The following is a description of a gene set: studied in species Homo sapiens Decreased body weight Abnormally low body weight. Human Gene Set: HP_DECREASED_BODY_WEIGHT, and this is the list of marker genes: BCL2, NDUFAF1, FTH1, COL6A1, PIGP, ATP7B, POU6F2, KARS1, TRAIP (NCBI Gene Id 10293), LUZP1, MBL2, SUGCT, GLI2, PNPT1, CCNF, NSRP1, DDC, HTRA2, RHBDF2, FBN1, LCK, EBF3, NEFH, TWNK, AK2, IL2RG, CIC, SHH, OTUD6B, COL1A2, SLC25A3, BRCA2, COX7B, EDNRA, PPP1CB, SPRTN, HADHA, RFWD3, CASZ1, CUL3, POLD1, SNCA, INSR, KLHL41, GLYCTK, NELFA, PALB2, TGFBR2, FARSB, NCAPG2, SLC25A22, ASNS, HACE1, DNA2, ALS2, TRIM37, XPC, CHEK2, PHKG2, TTR, IFNG, RELB, CA2, DPP9, CCDC47, POMP, PRNP, SZT2, SUCLG1, PIGA, COG8, CYP24A1, BANF1, SLC7A7, KCNN4, MAP3K20, CFAP410, NCF1, NDUFA2, NKX3-2, LPIN2, MALT1, TAC3, ITGAM (integrin subunit alpha M), RTTN, TET2, SIX3, PEX7, LRRK2, IFIH1, OBSL1, ICOS (NCBI Gene Id 29851), NDUFS2, ACTB, RPL5, TRIP13, SYK (spleen associated tyrosine kinase), FANCA, SMC3, ATP8B1, ADK (NCBI Gene Id 132), CYP19A1, RNU4-2, PKP1, EWSR1, SDHAF1, SIN3A, SHOC2, DTYMK, NPHP3, MRAP, TRAK1, ANKRD55, ROBO1 (roundabout guidance receptor 1), CTNNB1, NFKB1, FAM111A, COL4A6, TRAC, ZEB2, YWHAG, LAMA2, CDON, TACR3, CTRC, CA12, CHRNA3, CDKN1C, TBR1, PXK, PIGQ, KISS1 (KiSS-1 metastasis suppressor), SNIP1, ABCB11, HSD17B4, TLL1, TRMT1, YARS2, SIK1, PTRH2, NACC1, RPS15A, ZNF335, FANCD2, PEX19, PTEN, MT-TQ (NCBI Gene Id 4572), MARS1, BAP1, HACD1, MECP2, CAMKMT, MMAA, SIL1, CPSF3, WNT7B, MT-ND2, RPS29, PTH1R, SCN1A, ERCC5, NPM1, TCTN3, PPFIBP1, HLA-DRB1, ADA, FANCM, SPEN, AUTS2, DOCK6, HSD11B2, ANTXR2, PPP1R13L (protein phosphatase 1 regulatory subunit 13 like), POLG2, WDR73, PLCB1, GJA1, FANCC, EVC2, RFT1, NDUFS4, NAB2, SNORD115-1, SLC35C1, GLT8D1, IRF4, MS4A1, CRELD1, MT-ND6, KAT6B, NSUN3, STING1, AKR1D1, GATA2, PLP1, MBTPS2, DYNC2LI1, BCL6, GABRD, RPL35A, RPL26, STAT4, MEG3, ATP1A2, UBR1, EN1, MCCC2, SLC39A8, ZIC3, EARS2, VPS37D, NALCN (sodium leak channel, non-selective), GGPS1, BMP4, NNT, KCNB1, FCGR2A, GABRA2, DAO, HLA-DPB1, VIPAS39, HESX1, UNC13A, CRIPTO, ZNRF3, POLR3K, MMUT, TLR7, BSND, KIF15, LIN28B (lin-28 homolog B), TYMP, NOTCH2NLC, STT3B, TYMS (NCBI Gene Id 7298), FGFR1, CBS, HIBCH, MYO5B, NSF, ADAR, BSCL2, COX4I1, FANCL, NDUFAF6, SDHB, PRDX1, KISS1R, ARPC1B, MAP2K1, LIMK1, FLCN, LMNB1, MRPS7, CEP152, UQCRC2 (NCBI Gene Id 7385), ASPM, CHRM3, DHCR24, SYNJ1, VARS2, WDR26, DHDDS, AMACR, TMEM127, HADHB, ERBB2, DNASE2, PYCR1, HADH, GALT, ESAM, LAT, PEPD, WWOX, DEF6, NAGS (NCBI Gene Id 162417), BLK, TAF6, CHD7, ANKH, WDR4, CDT1, TGIF1, B4GALT1, CDKN2B, CENPT, COG4 (component of oligomeric golgi complex 4), MLX, CACNA1S, ALG6, BTNL2, CEP57, ATP9A, HCCS, MTRFR, MSH2, ALG11, ABCA3, PRF1, ATXN7, TIMMDC1, AP3B2, GTF2IRD2, PON1, IFT140, ALG8, STAG1, TOPORS, LETM1, NR3C2, FKBP6, FOXP3, JMJD1C, GCK, HPDL, RAC2, MATR3, SIGMAR1, DGAT1, VAC14, POMC, CELF2, CACNA1B, THRB, DGUOK, PRMT7, MYL2, FUS, GTPBP2, TGFB3, YY1AP1, RPL18, B3GLCT, ENPP1, SAMD9, NEUROD2 (NCBI Gene Id 4761), RNF2, FLI1, CAPNS1, GNB1, UBAP2L, NDUFA8, RPS20, MEFV, RPS19, PERCC1, FIP1L1, HNRNPH1, SLC1A2 (solute carrier family 1 member 2), VPS13B, ASH1L, KRT10, CDKN1A, IL1RN, NDUFS8, EHMT1, MTHFR, ASXL3, ERBB4, KRAS, AFG2A, TAFAZZIN, EIF2S3, ACADM, PPM1B, SLC39A7, PFN1, MMADHC, YIPF5, NOD2, HNRNPA1, TNPO2, TCF3, NSMCE3, SLC25A19, ASAH1, SLC3A1 (NCBI Gene Id 6519), ORAI1, SDR9C7, CNKSR2, FIG4, PREPL, PGM3, NSMF, EPAS1, SMARCC2, SLC6A8, PDHA1, NDUFAF3, NCAPD2, IL6, VAPB, GNAO1, PDE6D, KCNA4, TRIM28, IFNGR1, DOCK11, TNFRSF13B, PEX5, DNMT3A, KDSR, KRT1, LIG4, MT-TK (NCBI Gene Id 4566), NUDT2, POU1F1, GMPPA, TFAM, HLA-B, CNTNAP1, NDUFAF5, FBXL4 (NCBI Gene Id 26235), NF1, BICRA, TERT, C4A, POLG, ZFP57, PTCH1, MC2R, EXOSC3, PGAP1, GRB10, LARP7, MT-TF, NFKBIL1, ASS1, PRPH, DISP1, CEACAM6, PSMB4 (NCBI Gene Id 5692), NDP (norrin cystine knot growth factor NDP), SIX2, MAD2L2, PIK3CD, SSR4, PSMD12, IGF2, PML, SCNN1B, TMEM165, IL12A, RAG1, NRCAM, POC1A, FUT8, CERS3, LAMC2, CDK10, LMBRD1 (NCBI Gene Id 55788), EDN3, TRIM8, TREX1, SLC32A1 (solute carrier family 32 member 1), TRPV4, CPS1, TRIT1, SELENON, VPS45, DNM2, MED17, UBTF, PLCH1, DCTN4, OCA2, MUTYH, TALDO1, NDN, ATPAF2, CBL, SMOC1, MT-TV, FAS, BUB1B, GATA1, CDKN2C, SLC51A, IL23R, TINF2, BMP6, DDX3X, STAT3, IRF6, MARS2, SCN3A, SEMA4D, KMT2D, MVK, PSAT1, IGLL1, FGF17, ORC4, GRIN2D, FLT1, GHSR, SRD5A3, FOXH1, CPLX1, DCTN1, SBDS, CLMP, ECE1, KIT, ABCD1, DLST, IL2RB, CAVIN1, SEMA3D, C4B, SLC25A4, PPP2R3C, KRT16, PACS2, MCCC1, OCRL, EP300, PON3, HMOX1, RPL15, ACAT1, AGR2, MT-TL1, ACVR1, PROKR2, CLIP2, TBC1D24 (TBC1 domain family member 24), RRAGC, TRAPPC11, CTLA4, KCNJ1, GPR161 (G protein-coupled receptor 161), ATP1A3, P4HA2, GJA5, WRN, ATP7A, PLK4 (NCBI Gene Id 27119), DYNC2I1, GUF1, RPL11, PLCB4, ALDOB (aldolase, fructose-bisphosphate B), NOS1, SLC4A10, SLC1A3, BMPR1A, RPS24, NDUFA6, RNF168, UBE4B, SI, GRIN2A, SCO1, MYMK, NDUFB7, EBP, GATA6, VPS13C, SCN8A, GRIN1 (glutamate ionotropic receptor NMDA type subunit 1), BLNK, AKT1, CASR, CLCN3, GALK1, IL12B, ALOXE3, EPG5, PNPLA6, TGFB1, ANO1, SHROOM4, G6PC3, MYH7, BCOR, KRT14, F5, WDR62, BRF1, IGF1R (insulin like growth factor 1 receptor), NODAL, PMM2, MT-CO3, MAP2K2, SCN1B, CUBN, NDUFAF8, FCGR3B, TNFRSF13C, HFE, BCS1L, SLC30A9, TMEM106B, NDUFB11, DIS3L2, ALG12, PRKACA, VHL, FDXR, DNAJC19, SLC6A14, RILPL1, POLA1, PUS7, UBA5, ARID1B, CYP11A1, TOM1, IVD, NEDD4L, CNTN1, STIL, AMN, CD3D, RAB33B, RNU7-1, RRM1, ATP5F1A, SMARCAL1, ATP6V0A2, RBBP8, EEF1A2, COL7A1, ETHE1, BRD4, EXTL3, NFKB2, TNNT1, NEB, FGF8, TNFRSF11B, MCEE, GRM7, KIF22, DUSP6, WNT2B, PPARG, GALE, IPO8, CYFIP2 (cytoplasmic FMR1 interacting protein 2), TNFRSF1B, LARS2, MSMO1, DIAPH1 (diaphanous related formin 1), CYC1, TPM3, ASCL1, NCAPH, SCO2, COG1, RPL27, TOP3A, RARB, DDOST, B3GALT6, RNF13, SKI, CYP2R1, IGHG1, HS6ST1, CYP17A1, PTF1A, DLD, PPP1R15B, FLNA, STOX1, SLC9A6, CUL4B, DHCR7, DPAGT1, IDH1, NTRK2, HSPG2, MT-ND1, ADCY5, SPOP, GLE1, PUF60, EXOSC9, GTF2E2, ASL, FGF12, PSAP (NCBI Gene Id 83009), TPM2, OTULIN, AGXT, MTRR, GNRHR, PTPN22, RRM2B, PMS2, NUP54, USF3, MPL, GMNN, ANAPC1, TTN, MYH3, NEXMIF, SLC25A15, BMP1, FAH, UBE2L3, NFE2L2, THOC2, AMPD2, NDUFS7, TMEM231, RPS10 (ribosomal protein S10), ACD, NEUROG3, COL12A1, STAT5B, MAMLD1, MIF, PCNT, PWRN1, TMEM216, ANKLE2, PON2, CCNQ, SLC37A4, PDHB, ALG3, TLR4 (NCBI Gene Id 7099), AR, LAMB3, THPO, UNC80, CAD, CLCNKA, RPL31, RUNX1, CIITA, UMPS, RYR1, FANCF, STAR, COX10, IKZF1, PEX13, TMEM126B, PANK2, TIMM22, GIPC1, UPF3B (NCBI Gene Id 65109), JPH3, ATP6AP1, RABL3, JAGN1, MT-CO1, DLL1, GNPAT, FZR1, INTU, ALK, GTPBP3, SREBF1, POLR1B, NCAPD3, CHRNG, RAPSN, PACS1, CUL7, CLDN16, PEX16, RMRP (NCBI Gene Id 6023), TREM2, SUCLA2, STAMBP, SEC31A, EIF5A, TRMT10C, SLC11A1 (NCBI Gene Id 6556), NFASC, MAGEL2, FMR1, RNU4ATAC, KCNJ11, EIF2AK3, H4C5, ALG2, HBA2, ERCC3, ASXL1, EFL1, FANCB, CTBP1, KLLN, MRPS16, UFD1, CRIPT, COG7, SQSTM1, KBTBD13, SLC10A2, CYP27B1, RAD51, PROK2, NFU1, AGPAT2, PCGF2, WBP4, TSHR, MITF, COL1A1, PDPN (podoplanin), ZMPSTE24, ATR, FOCAD, LRRC8A, CASK, ATM, RFXANK, CIT, FOS, LYRM7, SLC26A2, SMO, XRCC2 (X-ray repair cross complementing 2), NECTIN1, GPC3, HIVEP2, MT-ND3, RPS7, VPS35 (NCBI Gene Id 91808), HEATR3, ESR2, SPP1, CACNA2D1, MUSK, POLR1C, NDUFB10, KIAA0586, ACADS, COG6, ALAD, BAZ1B, AP1B1, NGLY1, TCIRG1, PCCB, LGI3, AHCY, AGTPBP1, CD3G (CD3 gamma subunit of T-cell receptor complex), TAMM41, GPIHBP1, ATRIP, ITGA7, PQBP1, TASP1, CARS1, SPTSSA, ARFGEF2, PRKCZ, BRIP1, EXOSC8, HCFC1, UBE2T, LRP12, UQCRFS1, MRPS14, METTL5, BPTF, AAAS, AIMP1, GBE1, ERCC8, SON, NUP85, EFEMP1, INS, NADK2, RAB3GAP1, NDUFA1, SKIC2, SLC25A11, BIRC3, LIPA, NOTCH2, SLC16A2 (solute carrier family 16 member 2), GAS1, HAVCR2, ACADVL, SPTBN1, ZNF668, TMEM70, RPS17, MT-CO2, KIAA0319L, AFF3, NKX2-1, ERAP1 (endoplasmic reticulum aminopeptidase 1), RPS28, NDUFB3, STAT1, NDUFA13, TFRC, KCNQ2, IKBKB, NFKBIA, PHGDH, CDKN1B (cyclin dependent kinase inhibitor 1B), COL4A5, CDC73, CCR1, CSPP1, CYP7B1 (cytochrome P450 family 7 subfamily B member 1), FOXRED1, RAD51C, KCNJ18 (NCBI Gene Id 100134444), GLI1, ELMO2, COQ4, CDH23, MRPL39, MIPEP, CD96, PKHD1, SPINK5, PLAA, SATB1, ST3GAL5, CKAP2L, HNRNPK, UFC1, LYN, GBA1, IL21, BUD23, RIT1, HERC2, TCF4, XYLT2, FZD4, RERE, IFT56, GNPTAB, CRLF1, SLC34A3, TBL2, EIF4G1, MKKS, ADA2, ERBB3, NECAP1, RAD21, CSF2RA, PYCR2, AGPS, SLC9A3, PNP, NPHS1 (NPHS1 adhesion molecule, nephrin), ACTG1 (NCBI Gene Id 71), TBX1, PAM16, SPG11, GABRB2, ORC6, TGDS, ANOS1, SYNGAP1, PTPN11, NUMA1, GCLC, SMAD4, GCDH (NCBI Gene Id 2639), GYS2, CLTC, CR2, CTNS, XPA, SRP54, TNIP1, IQSEC2, SMAD2, GABRA3, LRRK1, HBA1, HIKESHI, CD244, HMGA2, LARS1 (NCBI Gene Id 56885), IGF1, IGHMBP2 (NCBI Gene Id 50985), PSMB8, COPB2 (NCBI Gene Id 9276), ATP6V1A, CYB5A, COX20, TNFAIP3, SH3TC2, HYMAI, RAI1, UQCC2, SLC46A1, UBAC2, ERCC4, GDNF, BRCA1, HNF1A, MYT1L, SRSF2, MTO1, GRIA4, SPTLC1, KRT17, DOLK, ALB, SLC25A24, SLC2A3, GLUD1, MDH2, SLC22A5, NDUFA11, MYL11, KIAA0753, DNM1L, CARMIL2, IRF2BP2, SLC5A1, TKFC, EGFR, AARS1, GALC, CD247, BTK, PBX1, TARDBP, NDUFS1, PWAR1, ABCD4, TBX4, KMT2C, MAP3K7, STRADA, DEGS1, AASS, SLC12A3, MPI, HRAS, RPS6KA3, SPI1, HLA-DQB1, SNAP29, SLC25A13 (NCBI Gene Id 10165), KDM5C, NUBPL, OCLN, SC5D, KCNJ6, SMARCD2, FGD1, CHMP2B, TNFSF12, TP63, TAOK1, ACOX1, GLB1, CNOT1, SGO1, IL21R, POLR1A, NDUFV1, POLE, SEMA4A (NCBI Gene Id 64218), DEAF1, SPINK1, CENPJ, MMACHC, TCN2, RPL8, TJP2, CREBBP, PMS1, KLF1, EOGT, ARCN1 (archain 1), NFIA, TUBB4A, GSTM3, NHLRC2, ACO2, SFTPC, SLC39A4, SLC13A5, SH2B1, DDB2, PUS3, UNC45A, HTT, CAV1, CD81, MLH1, NFIX, FH, NDUFA4, RIPK1, DRG1, VPS37A, UBA2, DOCK8, CLTCL1, CFTR, JAK1 (Janus kinase 1), STUB1, ABCC6, FOXP1, ERCC1, FLII, SMPD1, PEX12, JAG1, TRIO, GNRH1 (NCBI Gene Id 2796), NLRC4, PYGL, H3-3B, SLC26A3, CORIN, FBXO28, PLAGL1, DPYD, SLC38A3, MT-ND5, ZNFX1, GJA8, PEX1, CLCA4, MT-TN, ARVCF, SDHA, ANXA11, AUH (NCBI Gene Id 549), ACTL6B, CD79B, SOD1, ELAC2, DYM, TMPRSS15, PNPO, NDUFB8, FANCG, AMER1, OSGEP, PDX1, MT-ATP6, ALPL, DPP6, MSX1, DNM1, SPRY4, MPV17, MSH6, GOT2, DNAJC13, HNRNPH2, SMARCA2, KMT5B, RFX5, ITCH, DLL4, ALG13, PEX3 (NCBI Gene Id 8504), PSMC1, TONSL, REST, POR, ATP5F1B, PEX10, MCM4, AVPR2, ABCC8, VPS51, HUWE1, TAPT1, HLA-DPA1, GATA4, DKC1, KMT2A, KRT6A, CDC6, EMG1, TBC1D23, IL10, NR4A2, GTF2H5, RPL35, MKRN3, CHCHD10, PRDM16, EIF4A2, MT-TS2, KCNAB2, ACAD9, MECR, CSNK2A1, UBE3B, MPDU1, RARA (NCBI Gene Id 5914), PIK3CA, GTF2IRD1, CBFB, TBK1, PPARGC1A (PPARG coactivator 1 alpha), GOLGA2, NDUFS3, IGHM, SALL1, SNRPN (small nuclear ribonucleoprotein polypeptide N), GPR35, SNX10, CYP11B2, LMO1, STT3A, TXNRD2, IL12A-AS1, FOXG1, STX1A (syntaxin 1A), MAPKAPK5, CENPE, SLC12A5, GAA, PCLO, MCTP2, CDKN2A, SDHC, RFC2, ATRX, MCM9, VPS33B, PIK3C2A, MT-ND4, SETD2, SERPINA1, DLK1, ERMARD, SARS1, CCDC8, SEC23B, DYRK1A, MGAT2, YY1 (YY1 transcription factor), MEGF10, NDUFAF2, CDC45, CRLS1, TMEM270, UBQLN2, PEX6, SCN2A, NUS1, HBB, ARX, FUCA1, SLC2A2, ELF4, AVP, SLC34A2, RTEL1, SCNN1A, SLC35A2, ETS1, RBM10, RB1, CAMK2B, NCF2, RPL9, ADAM17, RBPJ, DPYS, PALLD, ZIC2, NUP214, DALRD3, LEMD3, RPS26, VRK1, STAT6, AHDC1, PCSK1 (NCBI Gene Id 5122), NR0B1, TSHB, FAM149B1, LMNA, ADNP, GJB3, PRKACB, STAG2, DMPK, POGZ, MYMX, IL7R, HSD3B7, WDR11, CD28, WT1, CDKL5, OTUD5, ANG, KCNA2, IKBKG, DNMT3B (NCBI Gene Id 1789), GALM, DNASE1, IRF5, ZBTB16, RFXAP (NCBI Gene Id 5994), VPS13A, NDUFAF4, MEN1, TNFSF4, DCLRE1C, STRA6, SETBP1, VCP, NLRP1, PEX2, TSR2, MBTPS1, GPD1, MYPN (NCBI Gene Id 84665), TAF13, ATP6V0A4, SV2A, JAZF1, RBCK1, TRMT10A (NCBI Gene Id 93587), VPS53, BCAP31, MRPS2, CPLANE1 (NCBI Gene Id 84157), LTC4S, JAK2, ELN, RECQL4, GNB2, VDR, PTS, JAK3, ZNF699, FBN2, NDUFV2, TAF15, PLAG1, SEMA3C, ORC1 (NCBI Gene Id 4998), EVC, MYOD1, CDK19, TBL1XR1, SFTPB, PIEZO2, BCL10, SERAC1, COX4I2, PEX26 (peroxisomal biogenesis factor 26), MICOS13 (mitochondrial contact site and cristae organizing system subunit 13), SDHAF2, TRMT5, GJB2, NHLH2, PTDSS1, COA8, FDFT1, IRF8, SOX9, H19, SLC12A1, CACNA1A, NIPAL4, PDCD1, GABRA5, ABL1, ACTA1, LIG3, SRCAP, DHX9, SLC34A1, ABCA12, AARS2, MAFB, CD3E, MMP23B, OFD1, IARS1, FCGR2B, SLC25A46, ZSWIM6, CYB5R3, MYCN, ERCC2, EPCAM, PSMB10, SKIC3, CARS2, KRT6B, NABP1, GIGYF2, AQP2, PHKA2, CD79A, GABBR2, RIN2, ALG9, GP1BB, CLCNKB (chloride voltage-gated channel Kb), SEC61A1, ACSL5, LONP1, DPM1, PDHX, TIMM50, SIM1, ABCB4, TPI1, NRAS, HLCS, LBR, SLC25A21, NDUFB9, SLC17A5, POLR3A, RAG2, GPT2, RARS2, RPS27, GJB6, NR1H4, PIGB, FOXN1, HLA-DQA1, DNAJC30, KCNT1, ABCB7, COQ7, DNAJC3, PAX2, PDGFRB, PRTN3, SPR, NAT8L, TWIST2, HSD3B2, KLRC4, SYT2, ALDH18A1, PUS1, MTR, PHOX2B, ERCC6, RET, SULT2B1, SLC22A4, RREB1, NIPBL, SURF1, HMGCL, PTPN2, ZAP70, ATP6V1E1, MLXIPL, LRBA, ARHGAP31, CCND1, NOTCH1, BRAF (B-Raf proto-oncogene, serine/threonine kinase), PPP3CA, PNKP, BANK1, NBN, NUP62, KCNA1, CD40LG, POLR1D, RTL1, HEXB, LYRM4, TRAF7 (TNF receptor associated factor 7), SDHD, NPAP1, RYR3, OTC, LINS1, GATM, CEACAM3, NEK1, EDNRB, MT-TW, PRKAR1A, NRTN, GABRG2, DSG1, GRIA3, NSUN2, HIRA, SARS2, HPD, MRPL12, ADH5, NDUFS6, KRT5, KCNC2, CASP8, FANCE, KDM6A, TP53, YARS1, BLM, NSD2 (NCBI Gene Id 7468), MT-CYB, ADAT3, SAR1B, COMT, DMXL2, NUP188, PARN (NCBI Gene Id 5073), DNAJC21, PNPLA1, PET100, SLX4, GTF2I, GFAP, LRPPRC, HDAC8, POLR2A, MRPL3, USP7, PTCD3, GJB4, SMC1A, PEX11B, EPRS1, TGM1, SYNE1, ALOX12B, CSF2RB, MCM5, PMPCB, TCOF1, C2orf69, CREB3L1, MED12, DACT1, PARS2, PEX14, PIGG, KANSL1, PI4K2A, KIF1B, HERC1, PCCA, MTTP (NCBI Gene Id 4547), TK2, CTCF, MMAB, MT-TH, SLC39A13, MADD, ITPR1, LRP5, MRPS28, ACSF3, SLC26A9, SNORD116-1, SP110, CDAN1, PIK3R1, TLK2, MST1, EIF4H (eukaryotic translation initiation factor 4H), COX5A, NONO, PRPS1, B2M, ATXN2, TRAPPC2, KIF7, IRF1, OPTN, DPM2 (dolichyl-phosphate mannosyltransferase subunit 2, regulatory), EHHADH, SCNN1G, B4GALT7 (beta-1,4-galactosyltransferase 7), GK, LAMA3, SLC4A1, HCN1, FANCI, IRAK1, RASGRP1, FGFRL1, CD19, LHX4, DSP, IL2RA, CALR, NSDHL, MAX (MYC associated factor X), SEC24C, FTO, METTL27